Given this list of marker genes FBLN5, AXIN2, FIGNL1, SMAD3, JUNB, ABL1, ITGAV, PLXNB1, RHOA, CCN1, MN1, SFRP1, OSR2 (odd-skipped related transciption factor 2), LRRC17, MUS81, IFT80, FGFR2, BCL2, MIR675, EIF2AK2, SOX8, ATRAID, LTF, ITGB3, LRP5, HPSE, NF2, NPR3, NELL1, MIR138-1, GREM1, GATA1, MIR9-1, BMP2, TMEM119, CTHRC1, here is a description of the gene set: Human Gene Set: GOBP_OSTEOBLAST_PROLIFERATION The multiplication or reproduction of osteoblasts, resulting in the expansion of an osteoblast cell population. An osteoblast is a bone-forming cell which secretes an extracellular matrix. Hydroxyapatite crystals are then deposited into the matrix to form bone. species: Homo sapiens